The following is a description of a gene set: Genes predicted to be targets of miRBase v22 microRNA hsa-miR-4274 in miRDB v6.0 with MirTarget v4 prediction scores > 80 (high confidence targets). Human Gene Set: MIR4274 from publication Chen Y, Wang X (PMID 31504780) studied in species Homo sapiens, and this is the list of marker genes: SESN3, RBM26, UBE2D2, FBN2, COL4A2-AS2, DPH6, PEX5, TPPP3, LOXL4, PDCD2, AGFG1, DYNC1LI2, ADARB1, RNF39, COL4A6, PLPP3, GIGYF2, MSL3, NRK, QKI, ZBTB24, PARD3B, COMMD2, GLRB, BTRC, RAPGEF2, BTF3, TRA2B (transformer 2 beta homolog), PCDH9, L3MBTL1, EIF3H, SLC25A31, MXRA5, ZNF367, IRF2, C6orf136, PAGE5, GABRA2, DCUN1D4, RAB14, MAT2A, NSL1, DOCK3, MECOM, ELL3, DYRK1A (NCBI Gene Id 1859), USP3, HDAC2, QSER1, SEC63, DHRSX, ATP5MG, CPNE8, TM9SF3, EXOC6B, DNM3, KCNIP2, GOLGA6C, PRKG1, MARK3, NT5C1B, RAB10